The following is a description of a gene set: The directed movement of a xenobiotic from a cell, into the extracellular region. A xenobiotic is a compound foreign to the organism exposed to it. It may be synthesized by another organism (like ampicilin) or it can be a synthetic chemical. Mouse Gene Set: GOBP_XENOBIOTIC_EXPORT_FROM_CELL species: Mus musculus, and this is the list of marker genes: Slc22a18, Abcb1a, Oscp1, Abcg2, Abcb11, Abcc1, Abcb1b, Slc47a1, Abca3, Ralbp1, Abcc2, Slc17a3, Slc47a2